Given this list of marker genes SPANXB1, CYTL1, SLC1A1, PDGFC, DKK3, CD24, SPANXC, KYNU, SPANXA1, SPANXA2, HSD17B2, SERPINE2, CRIM1, CXCL14, GREM1, BAMBI, ALDH1A1, AXL, NNMT, SCN3A, MYO10, SPOCK1, here is a description of the gene set: studied in species Homo sapiens Top genes up-regulated in the GIST (gastrointestinal stromal tumor) cell line resistant to imatinib compared to the parental cell line sensitive to the drug. from publication Mahadevan D, Cooke L, Riley C, Swart R, Simons B, Della Croce K, Wisner L, Iorio M, Shakalya K, Garewal H, Nagle R, Bearss D (PMID 17325667) Human Gene Set: MAHADEVAN_IMATINIB_RESISTANCE_UP KIT or alpha-platelet-derived growth factor receptor (alpha-PDGFR) activating mutations are the pathogenic mechanisms that characterize gastrointestinal stromal tumors (GIST). Despite excellent responses to imatinib mesylate (IM), patients are relapsing. We developed an IM-resistant GIST cell line (GIST-R) from the IM-sensitive GIST882 cell line (GIST-S) by growing these cells in IM. Gene expression profiling (GEP) of GIST-S, GIST-R cells and two IM resistant GIST patients demonstrated that KIT is downregulated implying a major role in IM resistance. Instead, GIST-R cells have acquired IM resistance by overexpressing the oncogenic receptor tyrosine kinase - AXL - in a 'kinase switch'. Further, the two IM resistant GIST patients express AXL and not c-Kit, seen by immunohistochemistry (IHC). Real time reverse transcriptase-polymerase chain reaction and Western blotting of the GIST-S and GIST-R cells confirmed the switch from Kit to AXL. In GIST-R, AXL is tyrosine phosphorylated and its ligand growth-arrest-specific gene 6 is overexpressed implying autocrine activation. The kinase switch is associated with a morphological change from spindle to epithelioid. Molecular modeling of the kinase domain of mutant c-Kit (V654A) and AXL showed no binding to IM but efficient binding to MP470, a novel c-Kit/AXL kinase inhibitor. MP470 synergizes with docetaxel (taxotere) and is cytotoxic to GIST cells.